The following is a description of a gene set: studied in species Homo sapiens Human Gene Set: GOCC_PROTON_TRANSPORTING_TWO_SECTOR_ATPASE_COMPLEX_CATALYTIC_DOMAIN A protein complex that forms part of a proton-transporting two-sector ATPase complex and catalyzes ATP hydrolysis or synthesis. The catalytic domain (F1, V1, or A1) comprises a hexameric catalytic core and a central stalk, and is peripherally associated with the membrane when the two-sector ATPase is assembled., and this is the list of marker genes: ATP6V1C1, ATP6V1C2, ATP6V1H, ATP6V1A, ATP6V1B1, ATP6V1E1, ATP6V1E2 (NCBI Gene Id 90423, ATPase H+ transporting V1 subunit E2), ATP6V1B2, ATP6V1F, ATP6V1G1, ATP6V1G2, ATP6V1G3, ATP6V1D